The following is a description of a gene set: Mouse Gene Set: MIR_7061_3P Genes predicted to be targets of miRBase v22 microRNA mmu_miR_7061_3p in miRDB v6.0 with MirTarget v4 prediction scores > 80 (high confidence targets). from publication Chen Y, Wang X (PMID 31504780) species: Mus musculus, and this is the list of marker genes: Rspo3, Arl8b, Sos1, Cpne8, Rap2c, Trim71 (tripartite motif-containing 71), Dcps, Crkl, Syt13, Serpinb9 (NCBI Gene Id 20723), Usp28, Zc3h12c, Spred1, Zfp91, Mbnl1, Ccnt2, 4930550C14Rik, Rnf111, Nuak1, Rictor, Zfp281, Ccdc91, Selenot (NCBI Gene Id 70512), Tomm70a, Rasa1, Tspan12, Zfp268, Nbea, Bcl2l13 (BCL2 like 13), Lhx8, Fbxw7, Fubp3, Acvr2a, Or7a38, Tmem200c, Cracd, Klhl21, Ing3, Osbpl9, Magi1, Fhl4, Wee2, Mbtd1, Pcdh9, Zfp202, Gabrg1, Ubr7, Mc4r, Fnip1, Ap1s3, Rbl1, Srsf7, Arl2bp, Lats2, Atl2, H2-M2, Wdr12, Cyp2j12, Chrna9 (cholinergic receptor, nicotinic, alpha polypeptide 9), Lpar1, Rnf166, Gpatch8, Dlg5, Arhgap35, C9orf72, Tmem50b, Fsd1l, Phf3, Dst, Clk2, Zfp984